Given this list of marker genes H2-M10.5, H2-Q10, H2-Q6, Tap1, H2-M2, Atp5f1b, Pilra, H2-T3, Pirb, Atp5f1a (NCBI Gene Id 52533), H2-T10 (NCBI Gene Id 15024), Klra17, H2-Q7, H2-Q2, Tap2, H2-D1, Cd244a, Derl1, H2-M10.1, Pdia3, Bcap31, H2-M10.6, H2-T22, H2-M11, H2-K1, Pilrb2, H2-T23, Mfsd6, H2-M10.3, Tubb5, Vcp, H2-Q1, Klrk1, Cd8b1, H2-M5, H2-Q4, H2-M1, H2-M10.4 (histocompatibility 2, M region locus 10.4), H2-M10.2, Pilrb1 (paired immunoglobin-like type 2 receptor beta 1), H2-M9, here is a description of the gene set: studied in species Mus musculus Binding to a major histocompatibility complex class I molecule; a set of molecules displayed on cell surfaces that are responsible for lymphocyte recognition and antigen presentation. Mouse Gene Set: GOMF_MHC_CLASS_I_PROTEIN_BINDING